Given this list of marker genes NPM1, PLK4, CEP295NL, STIL, POC1B, KAT2A, ALMS1, TRIM37, CDK5RAP2, VPS4B, CEP295, CENPJ, CCDC15, PPP1R35, CEP120, MDM1, PLK2, KAT2B, RBM14, C10orf90 (NCBI Gene Id 118611), CEP76, SPICE1, BRCA1, SASS6, NUP62, here is a description of the gene set: Human Gene Set: GOBP_REGULATION_OF_CENTRIOLE_REPLICATION species: Homo sapiens Any process that modulates the frequency, rate or extent of the formation of a daughter centriole of an existing centriole.